Given this list of marker genes THRAP3, RBMX, RBMXL1, UPF1, CDC73, RBMY1D, WDR77, CIRBP, SNW1, STH, PRPF19, EXOSC10, NCBP1, CCNB1, RBMY1F, UPF3A, PRDX6, NCL, PRMT5, RBMY1A1, NUP98, RBMY1E, DAZAP1, TRA2A, NCBP2, DHX36, CELF4, SNRNP70, RBMY1J (NCBI Gene Id 378951), CELF3, RBM3, TRA2B, CLNS1A, RBMY1B, UPF3B, HMX2, SLC39A5, here is a description of the gene set: Any process that activates or increases the frequency, rate or extent of mRNA processing. species: Homo sapiens Human Gene Set: GOBP_POSITIVE_REGULATION_OF_MRNA_PROCESSING